The following is a description of a gene set: species: Mus musculus part of: L1CAM interactions electronically inferred by orthology from the curated human pathway Reactome Pathway: Neurofascin interactions This event has been computationally inferred from an event that has been demonstrated in another species.<p>The inference is based on the homology mapping from PANTHER. Briefly, reactions for which all involved PhysicalEntities (in input, output and catalyst) have a mapped orthologue/paralogue (for complexes at least 75% of components must have a mapping) are inferred to the other species., and this is the list of marker genes: Sdcbp, Nfasc, Ank1